Given this list of marker genes GP1BA, COL1A2, GP9, VWF, COL1A1, GP5, GP1BB, here is a description of the gene set: Human Gene Set: REACTOME_ENHANCED_BINDING_OF_GP1BA_VARIANT_TO_VWF_MULTIMER_COLLAGEN Enhanced binding of GP1BA variant to VWF multimer:collagen studied in species Homo sapiens